The following is a description of a gene set: Human Gene Set: REACTOME_INTERLEUKIN_36_PATHWAY studied in species Homo sapiens Interleukin-36 pathway, and this is the list of marker genes: IL1F10, IL1RAP, IL36A, IL1RL2, IL36B, IL36G, IL36RN